Given this list of marker genes HNRNPAB, ABL2, MFSD12, ANPEP, DENND1B, CD69, PIR (pirin), PLEKHM2, TNFRSF4, KIFC3, PTS, NDUFB2, ICAM2, YTHDF3, CFLAR, ADA, HNRNPA3, USP6NL, CTDP1, MXD1, RBBP6, NRDC, RBM47, ARHGEF11, IRF7, FUT5, ZFYVE16, MFHAS1, LGALS3BP, PICALM (phosphatidylinositol binding clathrin assembly protein), ITPKC, NLRP3 (NLR family pyrin domain containing 3), NAA50, PPP1R15A, TGFBI, PTPN12, DNTTIP2, DOCK4, SMCO4, H3-3B, IL18RAP, SNIP1, SRC, CFAP410, PSEN1, C3AR1, SFRP5, DOHH, CASP4, ZBTB43, ESRRA, RAN, GRB2, CNIH4 (cornichon family member 4), PRKAG2, OSTM1, TENT5A, BATF, TWF1, ZC3HAV1, TFE3, HAND2, PRPF3, SLC38A6, TICAM1, MAP7D1, SNRPB, GADD45GIP1, LIMK2, HIF1A, CD48, DDA1, PLEKHO1, DYNC1H1, CASP3, DNAJB5, IFIT5, LUC7L, EREG, COL16A1, CEBPD, RIPK2, ILF2, G3BP2, HSPA6, DENND2D, PLAUR, ZCCHC2, GADD45B, CCNL1, SSB, NOD2, SP100, ACSL5, E2F3, CLN3, SRGAP2, SPHK1, ATP13A3, ELOC, NCOA1, ACSL1, FUZ, MAD2L1BP, IL1A, CD209, USP39, CALM1, LTC4S, WDFY3, HHLA2, IRS1, GLA, SLCO3A1, CD47, WNT5A, MRPL28, SHCBP1, TRIM21, LGALS8, MYO1E, HNRNPM (NCBI Gene Id 4670), RNASE1, ADAR, PHF11, IL36G, SATB1, CXCL3, STAT1, VDR, ARSD, YIPF6, DYNLT1, TIGAR, RNMT, PTPN2, PLIN3, IFITM2, CLCF1, RGS20, NINJ1, PTGER4, VEZF1, SMCHD1, RHEB, MARK3, OGFRL1, NSUN3, GCH1, MAFB, SLC2A6, FOXO3, CELA2A, UBE2D3, PSTPIP2, ELL2, MFN1, MMP19, FBLN2, SSTR2, DUOX1, TAP1, RNF19A, SFPQ, ELL, CDC37, SPSB1, SERTAD3 (NCBI Gene Id 29946), C1QB, JAK2, LILRB1, PAF1, FBXW7, CDS2, HSPE1, LRP12, TNFAIP6, MSL3, IFI44, ITGA9, EZH2, GPATCH2L, DNASE1L3, AGO2 (argonaute RISC catalytic component 2), SLC1A3, APOL2, IRF9, CYP1B1, F13A1, TNF, SETD1B (NCBI Gene Id 23067), HMOX1, CD53, OAT, TDRD7, TALDO1, FERRY3, MAP2K3, DDX39A, here is a description of the gene set: studied in species Homo sapiens Murine Cytomegalovirus (MCMV) infection leads to early activation of various immune cells, including B and T lymphocytes, before the actual initiation of antigen-specific adaptive immunity. This activation is partly driven by innate cytokines, including type I interferon (IFN), which are induced early after infection. The objective of this study was to address the role of type I IFN in shaping early/innate B and T cell responses to a primary acute viral infection. In order to decipher the specific impact of IFN-I on cell subsets, we performed a genome-wide expression analysis on WT splenic B and CD8 T lymphocytes isolated from C57BL/6 mixed bone marrow chimera mice. This study complements series GSE39555, which focused on early responses of NK cells and of the two subsets of conventional dendritic cells. Genes down-regulated in CD8A dendritic cells with IFNAR1 knockout: control versus primary acute viral infection. Human Gene Set: GSE45365_HEALTHY_VS_MCMV_INFECTION_CD8A_DC_IFNAR_KO_DN